The following is a description of a gene set: We combined large-scale mRNA expression analysis and gene mapping to identify genes and loci that control hematopoietic stem cell (HSC) function. We measured mRNA expression levels in purified HSCs isolated from a panel of densely genotyped recombinant inbred mouse strains. We mapped quantitative trait loci (QTLs) associated with variation in expression of thousands of transcripts. By comparing the physical transcript position with the location of the controlling QTL, we identified polymorphic cis-acting stem cell genes. We also identified multiple trans-acting control loci that modify expression of large numbers of genes. These groups of coregulated transcripts identify pathways that specify variation in stem cells. We illustrate this concept with the identification of candidate genes involved with HSC turnover. We compared expression QTLs in HSCs and brain from the same mice and identified both shared and tissue-specific QTLs. Our data are accessible through WebQTL, a web-based interface that allows custom genetic linkage analysis and identification of coregulated transcripts. species: Mus musculus from publication Bystrykh L, Weersing E, Dontje B, Sutton S, Pletcher MT, Wiltshire T, Su AI, Vellenga E, Wang J, Manly KF, Lu L, Chesler EJ, Alberts R, Jansen RC, Williams RW, Cooke MP, de Haan G (PMID 15711547) Transcripts in hematopoietic stem cells (HSC) which are trans-regulated (i.e., modulated by a QTL (quantitative trait locus) not in a close proximity to the gene). Mouse Gene Set: BYSTRYKH_HEMATOPOIESIS_STEM_CELL_QTL_TRANS, and this is the list of marker genes: Yap1 (NCBI Gene Id 22601), Eci1, Tmprss2, Sub1, Myo1f (myosin IF), Stat3, Pex5, Mbd3, Tec, Schip1, Igfbp5, Mmp17, Fus, Zdhhc5, Axin2, Ube2v2, Lbp, Nmt2, Slc1a5, Ibsp, 5730480H06Rik, Tpo (thyroid peroxidase), Impdh1, Trbv31, Kdelr1, Tnfsf12, Slc35g3, Ly6h, Psmd11, B3gat3, Ms4a4c, Itga6, Cox8c, Krtap5-25, Wipi2, Aldh1a7, Wipf1, Stx6, Gsk3a, Pafah1b2, Mtmr14, Il1rl1, Rock1, Hoxa1, Zfp746, Fastk, Kcna4, Mageb1, Ptpra, Krt4, Xrcc6, Akr1c6, Nog, Stat6, Cd48, Fancm, Skap2, Nbeal2, Svs6, Lef1, Ighv1-83, Nr2c2ap, Ipo8, Ankrd17, Rnf14, Park7, Rab4b, Trim21, Nucks1, Hand2, Dnajc7, Pde1a, Ctnnbip1, Ccl3, Kif5c, Traf6, Rfc5, Il1rn, Ddr1, 1700073E17Rik, Abcf1, Nacc2, Acp6, Smim20, Cd14, Zfp277, Slc25a19, Has1, Tmem129 (NCBI Gene Id 69753), Aldh1a2, Prkar1a, Rgs19, Hoxb13, Nkiras1, Dlx3, Map3k2, Gfra1, Cyp3a25, Smpd1, Cyth2, Gipc2, Cxcl10, Fgfr1, Efhd1, Il12b, Klc1, Rpl39l, Gja5 (gap junction protein, alpha 5), Cyp2c37, Atp1a1, Arl6ip4, Nusap1, Tomm70a, Gspt1, Fhod3, Usp39, Il18bp, Sirpa, H2ac18, Grin2c, Mpp1, Ndufv1 (NADH:ubiquinone oxidoreductase core subunit V1), Syngr1, Tor3a (NCBI Gene Id 30935), Muc17, Stk25, Phf13, Ahcy, Col17a1, Dicer1, Foxg1, Gas8, Ackr3, Trpm1, Vcam1, Fggy, Smg1, Inpp5e, Arpp19, Gltp, Zdhhc9, Snx10, Axin1, Esrra, Yipf4, Hnrnph2, Atp6v1e1, Foxred1, Ugcg, Csnk1e, 5031439G07Rik, Cdk8, Serpina3g, Rad17, Rnase2b, Il2rb, Slc4a4, Ang, Mrpl48, Limk1 (NCBI Gene Id 547389), Sft2d1, Mrpl13, Rala, Slc27a1, Mea1, Hrh1, Il6st, Cnot8, Itgav, Klk1b3, Hoxd1, Timm8b, Matr3, Polr2c, Lep, Tulp3, Igkv10-95, Abcb8, Gstm3, Npdc1, Mfhas1 (malignant fibrous histiocytoma amplified sequence 1), Hat1, Recql, Aktip, Prp2, Svs5, Tspo2, Ier3, Gabpb1, Tbc1d15, Ly6g, Cdc20, Fryl, Qsox1, Nppa, Pex14, Mnat1, Rbm18, Btf3, Ddx52, Nr2f6, Hdgf, Enpep, Gab2, Golt1b, Zfp36l1, Cacna1g, Rhox6, Cux2, Gipc1, Ebf3 (NCBI Gene Id 73115, early B cell factor 3), Zfp276, Omd, Nfkbie, Cdca7l, Zmynd8, Ndfip2, Dvl2 (NCBI Gene Id 13543), Slc30a9, Etv2 (ets variant 2), Scn1b, Cyp2c38, Fcgr1, Klrk1, Prom1, Chd1l, Cbl, Prr13, Synj2bp, Gm20772, Tie1, Pik3cd, Klf9, Pbx1, Ogdh, Pdcl3, Sirt3, Cox7a2l, Sepsecs, Glb1l, Abcb10, Setdb1, Kcnj1, Fdft1, Polr2i, Gys1, Zfp46, Snapin, Mia, Onecut1, Or13e8, Dgka, Itgb3, Fem1a, Naa15, Fgf18, Ak2, Impa2, Insl3, Mrpl28, B3galnt1, Serpina3c, Gyg1, Pwp1, Plxnb2, Tecta, Hnrnpr, Cuedc1, Pms2, Pip5k1b, Enc1, Cdo1, Mau2, Plrg1, Cfhr4, Hand1, Casp9, Wbp1, Dnase1, Rrp1, Rps6kb1, Cdh6, Eif2s2, Gdpd3, Mbp, Ran, Rpa2, Cd68, Sema6d, Preb, Blzf1, Muc5ac, Fzd3, Irf2bp1, Atp6v1b2, Gsta3, Vtn, Itsn1, Anpep, Zfp398, Sf3b6, Nfix, Sdhaf1, Dlg3, Ppp6c, Tlk2, Mapk7, Nmi, Pou5f1, Col4a1, Plxna2, Ptpn23, Prrx2, Cyct, Osbpl5, Gosr2, Zfp644, Tgoln1, Tuba1a, Fkbp9, Fbxw2, Car3, Mrpl12, Igkv8-30 (immunoglobulin kappa chain variable 8-30), Pttg1, Gpsm1, G3bp1, Adsl, Coq4, Gpc4, Cebpg, Hnrnpd, H2ac21, Psmd1, Uros, Csnk1d, Ccni, H1f6, Lig3, Rab23, Srsf10, Ndufc1, Garin5b, Krtap14, Kifc3, Xpo7, Tbxas1, Hoxb6, Trdv2-2, Cd40, Sox15, Rgl2, Glo1, Lrp8, Vegfc, Kcnq2, Colq, Ighv7-1, Meox1, Nlk, Vcl, Ctdsp2, Id2, Cradd, Wbp1l, Tpk1, Ccna1, Agfg1, Cyb5r1, Art2b, Hnrnpul2, Inha, Inpp5a, Ublcp1, Nfyc, Mpeg1, Cst9, Stk38, Slc25a44, Snrnp40, Fxyd3, Sgcd, Trbc1, Ubtf, Lilrb4b, Gar1, Cbx5, Mfsd14a, Akap17b, Wdr46, Hnrnpa1, AU040320, Arih2, Cavin3, Alk, Braf, Bmpr1a, Csrp1, Neu1, Cbfb, Capn7, Tmem199, Ncam1, Rap2b, Crkl, Selenok, Rad54l, Bid, Nefm, Zik1, Stau1, Sart3, Prrg2, 2410018L13Rik (RIKEN cDNA 2410018L13 gene), Ddah2, Npas1, Cyp2b10 (cytochrome P450, family 2, subfamily b, polypeptide 10), Rhod (NCBI Gene Id 11854), Rpp25l, Xpnpep1, Ywhag, Ccl4, Acvrl1 (activin A receptor, type II-like 1), Pdxk, Dcun1d5, Zfp936, Krt2, Acrbp, Gstk1, Npepps, Hr, Fnta, Adipor1 (NCBI Gene Id 72674), Stxbp2, Macrod2, H1f2, Gpr33, Th, Mdm1, Cntnap1, Pdrg1, Gngt2, Med22, Mapk12, Gast, Sct, Polr2g, Zfp61, Htra1, Map3k1, Zranb2, Xcl1 (chemokine (C motif) ligand 1), Nr2f1, Gpx1, Rbpj, Pramel6, Car5a, Lmna, Pipox, Ccl27a, Igfbp2, Rhoh, Chmp6, St7, Rag1 (NCBI Gene Id 19373), Comt, Slc16a7, Srrm1, Cd74, Sncb, Krtap13, Gria1, Chil3, Ceacam2, Psap, Gzma, Iyd, Htt, Reep1, Elovl2, Ddx56, Ndufaf1, Dnajb2, Gm5847, Rgs16 (NCBI Gene Id 19734), Tpp1, Josd2, Naxe, Cry2, Dus1l, Bcl7b, Npr3, Cacna1s, Htr1b (5-hydroxytryptamine (serotonin) receptor 1B), Fbln1, Psmd9, Chd1, Otp, Septin2, Atf2, Tnnt3, Acox1, Nefl, Mbd2, H19 (H19, imprinted maternally expressed transcript), Adprs, Nap1l1, Cul2, Phldb1, Timm10b, Tomm5, Mab21l2, Rora, Cyp4f13, Ndufv2, Serping1, Syt3, Ankrd2, Zfp703, Glns-ps1 (glutamine synthetase pseudogene 1), Il18r1, Cela2a, Eif5b, Col4a4, Cdh3, Gnas, H2-M9, Etl4, Wdr43, Nono, Cyp1a2, Ifitm3, Dync1h1, Mtor, Kctd9, Rab11b, Usp9x, Slc5a6, Fads1, Slc12a4, Cd79a, Lrrfip2, Bpifa2, Mrps34, Apbb1ip, Stk24, Man2a1, Oca2, Setd4, Fignl1, Nfkb1 (NCBI Gene Id 18033), Snx12, Adipoq, Ppp1r17, Prl2c2, Pcgf2, Mindy1, Pcyt1a, Igkv17-127, Tmem191, Hmgb1, 1810009J06Rik, Maf, Etf1, Coasy, Npnt, Fkbpl, Ctnnd1, Edn1, Pde4dip, Ifnar2, Usp19, Tyrp1, Hoxa2, Gucy2c, Sorbs3, Ppil2, Icam2, Plcb1, Mkrn1, Vldlr, Or2n1e, Arf3, Il13ra2, Cds2, Klk8, Nr0b1, Psmb7, 1810037I17Rik, Rwdd1, Gtf3a (general transcription factor III A), Tfrc, Aldh3a2, Csf3, Ahcyl, Esr1, Nip7, Cd320, Pde6a, Twist1, Hccs, Rasa4, Rgs11, Gm17811, Socs1, Zdhhc6, Pnck, Desi1, Pmm2, Prl7d1, Htr2b, Smndc1, Dhx9, Tcf3, Ptprn, Gstt2, Hipk2, Syk, Zfp518b, Uba5 (NCBI Gene Id 66663), Cript, Sp4, Star, Cp, Amy2a5, Trim43a, Amotl2, Ube2t, Terf2, Slfn2, H2-DMb2, Chrna6, Trap1a, Swap70, Adcy6, Twsg1, Grik1, Zc3h15, Dda1, Zfp688, Nagk, Rexo1, Cyp2c70, Sebox, Vegfb, Ikbkb, Hcfc1, Btbd17, Tut7, Arhgef28, Uhmk1, Nsdhl, Thbd, Cdx4, Notch4, Fyttd1, Akr1b8 (aldo-keto reductase family 1, member B8, NCBI Gene Id 14187), Copa, Dcps, Irf8, Slc25a14, Ift20, Scn8a, Mybl1, Adgrl1, Ttr, Stx4a, Grin2d, Tiaf2, Chrng, Wnt8a, Eif2ak3, Mrpl16, Extl3, H2az1, Nedd4l, Alas1, Selenof, Ptgfrn, Rtkn, Tnfaip8l1, Znrf2 (NCBI Gene Id 68858), Nr1d2, Lipe, Ube2z, Hsd3b1, Tfap2a, Vps26b, Cd5, Klra8, Hoxb4, Aurka (NCBI Gene Id 99385), Lpgat1, Gna13, Clk4, Il13, Ccl2, Ascl1, Crygd, Brd4, Mrpl54, Psmb5-ps, Itih3, Polr1c, Lmo1, Saa3, Tgfb3, Misfadt, Bmi1, Trbv12-1, Myo6, Cers2, Tspyl1, Sri, Adss2, Sprr2f, Atp6v1d, Tcirg1, Med24, Mobp, Ero1a, Rrn3, Edn3, Pcsk5, Bok, Stom (stomatin), Mcm3ap, Tspan12 (tetraspanin 12), Klk1, Brox (BRO1 domain and CAAX motif containing), Dntt, Syce2, Otulinl, Hsd3b2, Ift25, Echs1, Tnfrsf8, Proc, Luc7l, Zfp97 (zinc finger protein 97), Alkbh5, Irx3, Wnt7a, Crb3, Adam10, Capn2, Tcf4, Pcbp2, Cd34, C5ar1, Smad1, Rab11a, Ucp1, Btg1, Serpinf2, Arid1a, Rnf103, Rbpms, Ankrd46, Hcn2, Ccdc6 (coiled-coil domain containing 6), Serpind1, Tnfsf11, Ube2i, Snap23, Galr3, Tm2d2, Dnmt3a, Tns2, Rps23, Sec23ip, Plxnd1, Kcnd2, Pik3c2g, Mapkapk5, Eml5, Adarb1, Rad52, Atp6v1h, Lgals4, Col26a1, Cdkn3, Stx3, Hspd1, Pdcd1, Skic2, Eng, Ift27, Pgr, Igfbpl1, Nr5a2, Ighv1-77, Vav1, Vps37c, Sec14l2, Zkscan3, Tcstv1a, Mllt1, Setd1a, Haus3, Brd2, Naalad2, Msr1, Pla2g2c, Eif3b (eukaryotic translation initiation factor 3, subunit B), Mynn, Pak3, Tek, Cdx2, Vapa, Ghrhr, Glb1, Gbf1, Tfcp2l1, Sox2, Myo5a, Wbp2, Hinfp, Pik3r1, Tspan6 (NCBI Gene Id 77150), Ptk6, Pdxdc1, Ren1